The following is a description of a gene set: species: Homo sapiens Combining with glial cell line-derived neurotrophic factor and transmitting the signal from one side of the membrane to the other to initiate a change in cell activity. Human Gene Set: GOMF_GLIAL_CELL_DERIVED_NEUROTROPHIC_FACTOR_RECEPTOR_ACTIVITY, and this is the list of marker genes: GFRA3, GFRA1, GFRA2, GFRAL, GFRA4